The following is a description of a gene set: studied in species Homo sapiens from publication Wu HJ, Ivanov II, Darce J, Hattori K, Shima T, Umesaki Y, Littman DR, Benoist C, Mathis D (PMID 20620945) Human Gene Set: GSE22140_GERMFREE_VS_SPF_MOUSE_CD4_TCELL_UP A general defect of GF K/BxN T cell proliferation response toward antigen motivated us to look for the impairment in GF K/BxN T cells that might leads to the low Ab production and reduced disease phenotype seen in GF K/BxN mice. To find the difference between GF and SPF K/BxN T cells in a broad and non-biased fashion, we performed gene-expression profiling of these cells using microarrays. Genes up-regulated in healthy CD4 T cells: germ free versus specific pathogen free., and this is the list of marker genes: CD47, C1QB, PIM1, FYB1, BLZF1, IFIT2, GEM, TRIM22, WDR7, PML (NCBI Gene Id 5371), CCL18, CCL8, TRAFD1, CASP10, SBNO2, IFI35, COX6B1, FCGR1A, OAS2 (NCBI Gene Id 4939), TRIM21, SASH1, ARNT2, IFIT3, POLG, DDX5, WARS1 (tryptophanyl-tRNA synthetase 1), NPY, SOCS3, XAF1, UBE2L6 (ubiquitin conjugating enzyme E2 L6), SP110, ANAPC10, JMJD6, PCYT1A, SAMD4A, DNM1, HHLA1, TLR1, BCL2A1, FURIN, SH2B2, SCO2, VPS9D1, TRIB1, PDE4DIP, CCL13, CXCL11, RAB27A, SFT2D2, RNF19B, TTN, P2RX4, TAP2, TBKBP1, DNAJC13, KIF2A, IFI27, IFI44L, PTPRR, CLIC1, CTSZ, FZD2, RERE, CCNA1, IL3RA, ARID5A, XPO6, IFNA1, BMP3, CD69, C1S, CSF2RB, TNFSF10, TAP1, HESX1, ACSL1, CXCL9, SSTR2, BCL3, EDEM1, IRF1, NECTIN2, HOMER2 (homer scaffold protein 2, NCBI Gene Id 9455), DNAAF11, ZC3HAV1, MAK16, PTPN2, ZFP36, LEF1, MVP, TRIL, DEFB1, FLOT1, CDKN1A, SLC31A2, PLEK, CIITA, NAPA, SOCS1, IRF8, LCP2, OAS1, TRIM25, MAGEA11, TOP6BL, APOBEC3F, RAB5C, SP100, CD86, CRLF1, SAFB, MX2, PITPNB, PSMB3, KLF6, APOL1, ASGR2, PASK, IRF4, STK3, ANKS1A, ICAM1, GBP1, DYRK4, IRF7, B4GALT5, CUL1, IRF9, SERPING1, TRIM26, TNFRSF1A, STAT2, ERLIN1, NPC1, IFI44, PLAAT4, CCRL2, P2RY14, JUNB, TNFAIP2, IFI16, GK, RBM4, LIMK2, HEG1, CCL7, MX1, DMTF1, CTNS, IFIT5, TOP1, TNF, RSAD2, DDX23, VWA8, SECTM1, SMPD1, UBE2S, ISG20, GADD45B, NCOA1, AIMP2, PITPNA, NUCB1, HCK, BCL2L11, MAGED1, GDI2, ATP1B1, TDRD7, ISG15, EIF4A3, VAMP5, LAMP1, GCLM, PDGFB, LMO4, GLUL, IL10RA, IFITM1, PCK2, RBCK1, KLF4, CASP4, HIVEP2, CD96, DUSP5, GCH1, MRC1 (mannose receptor C-type 1), OASL, BATF, IDO1, CD7, CXCL10, GBP2, STX3, NAA80, CREM, MACF1